Given this list of marker genes JPH2, PLCZ1, SAP30L, PLEKHA5, SNX3 (sorting nexin 3), OBSCN, WASHC2C, TOM1, SNX5, PLEKHF1, PLA2G4A, SNX24, RUBCNL, SESTD1, LANCL2, SH3PXD2A, PHLDA3, PLA2G4E, VEPH1, WIPI2, SH3PXD2B, here is a description of the gene set: species: Homo sapiens Human Gene Set: GOMF_PHOSPHATIDYLINOSITOL_5_PHOSPHATE_BINDING Binding to phosphatidylinositol-5-phosphate, a derivative of phosphatidylinositol in which the inositol ring is phosphorylated at the 5' position.